The following is a description of a gene set: Human Gene Set: GOBP_PIGMENT_ACCUMULATION The aggregation of coloring matter in a particular location in an organism, tissue or cell, occurring in response to some external stimulus. species: Homo sapiens, and this is the list of marker genes: BLOC1S3, BLOC1S5, ANKRD27, CD63, SHROOM2, AP1M1, RAB32, AP1G1, AP3D1, RAB38, BLOC1S6, SHROOM3